The following is a description of a gene set: studied in species Homo sapiens The transcription factor Foxp3 is usually considered the master regulator for the CD4+CD25+ Human Gene Set: GSE7460_CTRL_VS_TGFB_TREATED_ACT_TCONV_UP from publication Hill JA, Feuerer M, Tash K, Haxhinasto S, Perez J, Melamed R, Mathis D, Benoist C (PMID 18024188) Genes up-regulated in comparsion of ActCD4 versus ActCD4TGF (see Fig. 1 in the paper for details)., and this is the list of marker genes: TMEM229B, GRAP, PDIK1L, IL4, APP, MAN1A1, PRSS54, SHISA4, POU2AF1, MAP3K20, NUFIP2, IRF6, CD44, PIWIL1 (NCBI Gene Id 9271), ADAM2, ENTPD5, CENPA, LGALS3BP, SDR16C5, FPR3, DTD1, DDC, NYAP1, EEF1AKMT2, DHCR24, SUSD1, GSPT2, LARP4B, ANGPTL1, MBOAT1, BEX1, TECPR2, SLC46A3, SYT3 (NCBI Gene Id 84258), ACTL6B, IL18RAP, DAP, CD28, DGLUCY, ANXA1, DAPL1, TBL1X, VCPIP1, RUNDC3B, SPEF1, XPO7, DYNC2LI1 (dynein cytoplasmic 2 light intermediate chain 1), ARHGAP28, ADRB1, ST6GALNAC2, SLC6A9, CENPW, MSANTD1, LY9, STARD6, NIPA1, GNAL, SLPI, SCGN, RGS5, DPP4, CD9, ENKUR, LRCH1, UNC119B, IQSEC1, GHITM, SH3D19, SPOCK2, EIF2AK3, GIMAP7, EPHB6, OR51B4, WDSUB1, CNGA1, SEMA5B, MUTYH, GCC2, MIA2, ZDHHC18, ITGB3 (integrin subunit beta 3), HDGF, OLIG1, SMAD3, AIPL1, SLC30A7, POLRMT, PRR16, MAPK12, TOP3A, TMEM51, MCOLN2, ANGPTL4, CYB5R1, NGLY1, ASPM, TRIM66, KCNQ5, DHCR7, HEMGN, SLC30A4, PIM2, EXOSC6, ATP8B4, GPAT3, MYO6, IMPDH1, CDYL2, GPR137B, FCER1A, HRH2, CALHM6, MOB3B (MOB kinase activator 3B), ARHGEF6, GBP6, IL7, RAPGEF5, PKP4, CD53, ITPR1, CYSLTR1, C2CD5, UGT3A2, ANKRD27, EVI2B (NCBI Gene Id 2124), MFSD6, EPS15, C3orf38, PPP4R1, TUBA1A, SNX9, EMB, TNFSF14, TTLL12, ROPN1L, BHMT, KRTAP2-4, CELF5, SIPA1L1, KIF2A, OCSTAMP, ERO1B, CYP20A1, LYST, NFE2L2, SYTL2, SEMA4A, RAB31, GPM6B, MRTFB, ZCCHC8, HSDL1, MCTP2, FZD5, MCOLN3, FRMD6, LMOD1, DPH5, GNG12, PLXND1, MCPH1, LBR, KIF3A, CENPE, POLH, PRDM1, VKORC1 (NCBI Gene Id 79001), ARHGAP29, IL12RB2, RALGPS2, GGH, BTLA, ENPP1, ZNF365, KCTD12, MORN4, KLF6, RHEBL1, NAP1L1, PRXL2A, NAAA, MTHFS, SRGN, HNRNPA1, PRR11, EVI2A, RDM1, HSPA1L, DZIP1, SLC38A1, COL17A1 (collagen type XVII alpha 1 chain), PCDHB13, FBXO33, TUBB2A, WDR3, PTPN22, ITK, NDST3, ZNF280B